The following is a description of a gene set: Acute hepatic failure species: Homo sapiens Human Gene Set: HP_ACUTE_HEPATIC_FAILURE Hepatic failure refers to the inability of the liver to perform its normal synthetic and metabolic functions, which can result in coagulopathy and alteration in the mental status of a previously healthy individual. Hepatic failure is defined as acute if there is onset of encephalopathy within 8 weeks of the onset of symptoms in a patient with a previously healthy liver., and this is the list of marker genes: MST1, ACAD9, SH2D1A, RINT1, POLG, CACNA1S, CYC1, ITCH, POLG2, TCF4, IKZF1, IL18BP, GPR35, CALR, MPV17, F5, SCYL1, JAK2, HLA-B, RYR1, PORCN, TRMU, MEFV, ZNFX1, HADH, SEMA4D, EIF2AK3, ATP7B, LARS1, NBAS, LIPA, KRT18, XIAP, FAH, GFM1